Given this list of marker genes MIR20B, MIR93, MIR504, MIR199A1, MIR34A, MIR874, MIR140, MIR16-1, SARS1, MIR15A, MIR17 (microRNA 17), MIR146A, MIR20A, MIR372, MIR106A, MIR107, MIR302D, MIR205, MIR125A, MIR373, MIR147A, MIR520G, MIR195, MIR15B, MIR134, MIR378A, MIR520H, MIR361, here is a description of the gene set: Any process that stops, prevents or reduces the frequency, rate or extent of vascular endothelial growth factor production. Human Gene Set: GOBP_NEGATIVE_REGULATION_OF_VASCULAR_ENDOTHELIAL_GROWTH_FACTOR_PRODUCTION studied in species Homo sapiens